The following is a description of a gene set: studied in species Homo sapiens Human Gene Set: SHAFFER_IRF4_TARGETS_IN_PLASMA_CELL_VS_MATURE_B_LYMPHOCYTE from publication Shaffer AL, Emre NC, Lamy L, Ngo VN, Wright G, Xiao W, Powell J, Dave S, Yu X, Zhao H, Zeng Y, Chen B, Epstein J, Staudt LM (PMID 18568025) IRF4 target genes up-regulated in plasma cells compared to mature B lymphocytes. The transcription factor IRF4 (interferon regulatory factor 4) is required during an immune response for lymphocyte activation and the generation of immunoglobulin-secreting plasma cells. Multiple myeloma, a malignancy of plasma cells, has a complex molecular aetiology with several subgroups defined by gene expression profiling and recurrent chromosomal translocations. Moreover, the malignant clone can sustain multiple oncogenic lesions, accumulating genetic damage as the disease progresses. Current therapies for myeloma can extend survival but are not curative. Hence, new therapeutic strategies are needed that target molecular pathways shared by all subtypes of myeloma. Here we show, using a loss-of-function, RNA-interference-based genetic screen, that IRF4 inhibition is toxic to myeloma cell lines, regardless of transforming oncogenic mechanism. Gene expression profiling and genome-wide chromatin immunoprecipitation analysis uncovered an extensive network of IRF4 target genes and identified MYC as a direct target of IRF4 in activated B cells and myeloma. Unexpectedly, IRF4 was itself a direct target of MYC transactivation, generating an autoregulatory circuit in myeloma cells. Although IRF4 is not genetically altered in most myelomas, they are nonetheless addicted to an aberrant IRF4 regulatory network that fuses the gene expression programmes of normal plasma cells and activated B cells., and this is the list of marker genes: ATF3, UBE2J1, CCL3 (NCBI Gene Id 6348), F12, NDRG1, NFIL3, SSR1, CAV1, UCK2, SLC12A4, PIM2 (NCBI Gene Id 11040), CASP3, KRAS, TNFRSF17, SUB1, ZFP36, DNAJB9 (NCBI Gene Id 4189), CCPG1, VEGFA, LDLR, PAM, CFLAR, APOBEC3B, HSP90B1, SORT1, TERT, BMP6, PDIA4, ELL2, NR4A1, TM9SF4, C11orf24, B3GNT2, AMPD1, ACP1, UAP1, FKBP11, PABPC4, HSPB1, AGPAT2, SLC3A2, AVPI1, DUSP5, PRDM1, TXNDC5, PCYT1B, BMI1, FZD2, TUFT1, NAMPT, IRF4 (NCBI Gene Id 4592), CANX, DDIT3, SPATS2, TRAM1, SLAMF7, MAN2A1, BSPRY, GFPT1, ITPKA, TNFRSF12A, CD38, TNFAIP3 (TNF alpha induced protein 3), PDK1, DNAJB5, ATF4, TIMP2